Given this list of marker genes Dnajc10, Pdia6, Dnajb11, Mzb1 (NCBI Gene Id 69816), Hsp90b1, P4hb (prolyl 4-hydroxylase, beta polypeptide), Sdf2l1, Ppib, Hyou1, Ugt1a1, Pdia4, Hspa5, here is a description of the gene set: Mouse Gene Set: GOCC_ENDOPLASMIC_RETICULUM_CHAPERONE_COMPLEX studied in species Mus musculus A protein complex that is located in the endoplasmic reticulum and is composed of chaperone proteins, including BiP, GRP94; CaBP1, protein disulfide isomerase (PDI), ERdj3, cyclophilin B, ERp72, GRP170, UDP-glucosyltransferase, and SDF2-L1.